The following is a description of a gene set: studied in species Homo sapiens Temporal analysis of B cell activation in vitro using CD40L and IL-2/4/5 cytokines in wild type Irf4+/+ B cells or in mutant Irf4-/- B cells harboring a tet-inducible allele of Irf4. IRF4 expression was restored, or not, in the Irf4-/- background by culturing in the presence of low or high concentrations of doxycycline. The results provide insight in the role of IRF4 expression levels in coordinating different programs of B cell differentiation. from publication Ochiai K, Maienschein-Cline M, Simonetti G, Chen J, Rosenthal R, Brink R, Chong AS, Klein U, Dinner AR, Singh H, Sciammas R (PMID 23684984) Genes up-regulated in at day 0 B cell IRF4-KO versus CD40L and IL-2 IL-4 IL-5 stimulated at day 1 B cell IRF4-KO. Human Gene Set: GSE46606_UNSTIM_VS_CD40L_IL2_IL5_1DAY_STIMULATED_IRF4_KO_BCELL_UP, and this is the list of marker genes: SMCO4, TIMM9, CCL5, HLTF, MAN1C1, SPRED1, FERRY3, KCTD12, FKBP1A, SHISA5, TRIP6, TTC38, DCPS, POLD1, TP53RK, KCNN4, KRR1, DAGLA, RILP, SUOX, FIGNL1, EVL (NCBI Gene Id 51466), XAF1, GBP5, DIAPH1, NOB1, ZNF330, DOCK1, DUS1L, PTER, TRIB2, HOMER1, NARS2 (NCBI Gene Id 79731), PLPP6, ALDH1A2, NDP, NSFL1C, UBE2E2, MYT1L, SNU13, RABGGTA, UBAP2L, CCDC86, ADCY7, MANBAL, AK2, APEX2, ST6GAL1, FBXO41, ATP13A1, IFI6, RTP4, DENND4B, VSIG10L, LGALS9, SUCNR1, CCND3, PRKACB, SNX20, TERF2, CARD9 (NCBI Gene Id 64170), STAT1, DNMT1, HERC5, RPL22L1, SLC20A1, SLC43A3, UTP4, CYTH4, NME1, MFN2, IL1RN, CCR1, EXOSC4, ZNF512B, IRF8, CCL2, BATF2, PARP9, ENPP2, G6PD, JCAD, MFNG, MAP3K21, BBS4, LPL, EEF1AKMT1, ADAT2, CBFA2T3, NCLN (nicalin), PRMT5, UBA7, SLC17A9, POLM, KCTD6, ASTE1, CALCOCO2, IL1RAP, DENND4C, HDHD5, RAC2, SF3B3 (NCBI Gene Id 9661), DUSP23, PRPF19, TEP1, MAPKAPK3, MYOF, ARHGEF6, TIFA, HK3, CISD1, KATNB1, TMEM109, RRP12, VWA8, PAICS, DESI1, CCL8 (C-C motif chemokine ligand 8), EGR2, ARHGAP18, HSP90AB1, CH25H, GSPT2, PA2G4, SLAMF8, MYC, ISG20L2, CRYBG3, CD53, EPOP, MDN1, DDX18, SNAI3, MEF2A, S100A11, CCR5, UNG, PDLIM4, ITGAX, KLHL8, SRRD, NAGK, CALHM6, CMTM2, NF2, PSMB8, F13A1 (coagulation factor XIII A chain), FAM210A, SPG21, IFI16, HAVCR2, FNIP2, SRM, PRKD3, CDK4, SPATS2L, PMM2, GATM, MAP2K6, UCHL3, CYSLTR1, PYCARD, GINS3, C11orf24, SHQ1, LRRC8C, SP110, TTLL12, VAMP1, FLVCR2, ATP1A1, ZNF585B, TRIM5, GLMN, MRPS30, JADE1, STAC3, CCDC14, IMP4, DCSTAMP, NAT10, SLC7A8, SLC66A2, FARSB, EBPL, PRELID1, TRIM14, COPS7A, ZNF738, SP140L, ATP6V0E2, SASH3, TNFRSF12A, RNASET2, TEX261, SSRP1, ASPH, BST2, PDZD11, FERMT3